Given this list of marker genes ARPC2, ACTG1, ARPC1A, WASF2, ARPC5L, ARPC3, ACTB, ACTR3, ARPC1B, ARPC5, ACTR2, ABI1, ARPC4, RAC1, here is a description of the gene set: Escherichia EspT to RAC signaling pathway. Pathway ID: N01086. Pathway type: Pathogen. Pathway class: nt06135 Cytoskeletal regulation (viruses and bacteria). Pathway Definition from KEGG: EspT -> RAC1 -> (WASF2+ABI1) -> ARP2/3 -> (ACTB,ACTG1) species: Homo sapiens Human Gene Set: KEGG_MEDICUS_PATHOGEN_ESCHERICHIA_ESPT_TO_RAC_SIGNALING_PATHWAY